The following is a description of a gene set: Human Gene Set: REACTOME_EXTRA_NUCLEAR_ESTROGEN_SIGNALING species: Homo sapiens Extra-nuclear estrogen signaling, and this is the list of marker genes: MAPK3, PIK3CA, BTC, CCND1, ESR2, GNB3, SPHK1, AREG, GNG2, GNG7, CAV2, ESR1, PTK2, EPGN, HSPB1, PIK3R1, MMP7, GNG4, PIK3R3, GNG10, GNG13, MAPK1, NOS3 (NCBI Gene Id 4846), AKT3, PDPK1, KRAS, CDKN1B, GNG12, GNG8, PIK3R2, ELK1, FOS, GNB2, GNG3, PRMT1, GNB4, SRC, GNAI2, IGF1R, SRF, AKT1, PRKCZ, GNAT3 (G protein subunit alpha transducin 3), GNB5, FOXO3, AKT2, ZDHHC21, CALM1, NRAS, ZDHHC7, MMP2, GNB1, S1PR3, CREB1, GNAI1, STRN, TGFA, HBEGF, CAV1, GNAI3, GNG11, HRAS, GNGT2, XPO1, HSP90AA1, EREG, BCL2, GNG5, MMP9, UHMK1, GNGT1, SHC1, MMP3, EGF, EGFR